The following is a description of a gene set: Binding to a DNA-binding transcription factor, a protein that interacts with a specific DNA sequence (sometimes referred to as a motif) within the regulatory region of a gene to modulate transcription. Mouse Gene Set: GOMF_DNA_BINDING_TRANSCRIPTION_FACTOR_BINDING studied in species Mus musculus, and this is the list of marker genes: Nhlh2, Med12, Nkx2-1, Gsk3b, Trp53bp1, Kmt2a, Ahr, Stat5b, Csrp3, H2bc23, Ar, Tbx5, Ywhah, Tcp10b, Ctbp2, Daxx, Bud31, Nbn, Fkbp4, Ipo13, Ifi27, Ttc8, Arrb1, Wipi1, Kat8, Cdk5rap3, Hcfc1, Tcerg1, Atf4, Smad3, Lmo2, Ankrd1, Flna, Mettl23, Lmo1, Taf4b, Rnf4, Lrif1, Ddx54, Ptprt, Nr1h3, Kat5, Cbx3, Mkks, Csnk2b, Psmc5, Src, Zfp703, Id4, Mef2c, Prrx1, Usf2, Jund, Cebpg, Prdm5, Nfyb, Ncapg2, Gbx2, Pramel13, Dll1, Nucks1, Sirt2, Hsd17b10, Ctcf, Lef1, Crebbp, Esr1, Nfatc1, Ski, E2f1, Setd6, Txlng, Rbx1, Klf5, Bcor, Prkdc, Gtf2i, Smarcd3 (NCBI Gene Id 78383), Hdac3, Map3k7, Ddx5, Trib1, Med1, Foxl2, Rbbp8, Sra1, Pias1, Bbs7, Kdm3a, Cebpb, H2bc9, Arnt, Npm1, Ets1, Hdac2, Gata6, Hey2, Epas1, Sox2, Crtc2, Lmo3, Hspa1a, Ankrd42, Hira, Tcf15, Flt3, Bmyc, Satb1, Gtf2a2, Sumo2, Tcp10a, Nkx3-1, Yap1 (yes-associated protein 1), Bex2, Arnt2, Creb3, Cnot7, Ptma, Bcl3, C1d, Tal1, Brms1, Park7, Rxra, Hmga1b, Sall1, Cited2, Mtdh, Wbp2, Zbtb17, Runx1t1, Cdkn2a, Hhex, Tbx2, Tcf7l2, Commd7 (COMM domain containing 7), Hes6, Prdm13, Bbs1, Fus, Hcls1, Fiz1, Dnaaf4, Gata1 (NCBI Gene Id 14460), Mad2l2, Sp1, Tpt1, Hnf4a, Crtc3, Tead3, Uhrf2, Faf1, Nr1i2, Tle4, Apex1, Sik1, Jun, Rbfox2, Tada3, Tbx20, Ncor2, Hdac1, Kat6a, Lhx3, Nup62, Trip4, Sp3, Smarca1, Zfpm1, Rnf25, Asah1, Uba3, Nfkbia, Bcl2, Lcor, Nrip1, Magea10, Usf1, Zbtb7a, Dhx33, Pitx1, Tcp10c, Sox8, Magea2, Mdfic, Id3, Smarce1, Nr1h2 (nuclear receptor subfamily 1, group H, member 2), Tcf3, Trim24 (tripartite motif-containing 24), Nfia, Rps6ka1, Bhlhe40, Myod1, Smad2, Hey1, Kpna2, Cpne1, Trp73, Bcas3, Chd4, Nr0b1, Hdac9, Wfs1, Ppid, Smarcb1, Parp1, Rnf6, Rest (RE1-silencing transcription factor), Arid5a, Tdg, Anxa4, Bcl11a, Mlxipl, Hoxa7, Magea5, Kat2b (NCBI Gene Id 320956), Runx1, Ascl2, Lrp2, Mixl1, Ctbp1, Taf9, Kdm1a, Noc2l, Med17, Nr4a1, Mdfi, Bbs2, Ywhaz, Lmo4, Gata2, Dhx9, Ddrgk1, Tfdp1, Zbtb49, Fbp1, Pagr1a, Nkx2-5, Lats1, Stat5a, T (brachyury, T-box transcription factor T), Nr4a2, Psma6, Zbtb8a (zinc finger and BTB domain containing 8a), Tcf4, Srarp, Notch2, Cggbp1, Ube2i, Bcl6, Isl1, Rarb, Nif3l1, Ifrd1, Pdcd11, Nrbf2, Cry2, Hif1a, Atf2, Pou4f1, Irx5, Prdm16, Foxa1, Vdr, Foxh1, Trim68, Stat3, Fam220a, Hsf1, Cnot1, Dapk3, Scx, Med24, Map3k10, Mms19, Ppara (peroxisome proliferator activated receptor alpha), Trip12, Cxxc5, Ankrd2, Trerf1, Nsd1, Hif1an, Trp53bp2, Tmf1, Grm1, Vhl, Thrap3, Nlrp3, Cbx5, Dnaja1, Ciita, Ep300, Cenpf, Nr1h4, Zfp473, Actn4, Wwp2, Purb, Taf12, Dusp26, Mlx (MAX-like protein X), Psmd9, Dcaf13, Rbx1-ps, Zfp653, Tbx6, Pbx2, Kdm4c, Nr4a3, Figla, Brd8, Tgfb1i1, Apbb1, Aip, Hr, Ccnt1, Sp100, Ddx20, Eomes, Bbs10, Pitx2, Hipk2, Taf10, Tcf23, Zfp366, Foxc1, Icmt, Hspa4, Prmt2, Gsc, Tacc1, Ppard, Fos, Foxp3, Twist1, Ncoa2, Sin3a, Med13, Keap1, Dhrs7b, Tbp (TATA box binding protein), Strn, Magea4, Mecr, Pou1f1, Eif4e, Myocd, Bhlhe41, Prkcb, Tob2, Tbx18, Calr, Snw1, Arid1a, Gtf2b, Hmgb2, Grhl2, Dnmt3a, Ncoa1, Ldb1, Sri, Ctdp1, Hdac5, Elk1, Zfpm2, Nr0b2, Ddit3, Ubxn7, Dmap1, Exosc9, Parp10, Bbs5, Ccdc62, H2bc24, Taf1, Hdac8, Mta2, Sox17, Dgkq, Fhl2, Smad4, Klf4, Kdm5c, Dcaf1, Stk4, Crkl, Pou5f1, Tbx3, Pbxip1, Cd34, Runx2, Hoxc13, Uimc1, Sost, Tcf21, Dnaja3, Crtc1, Rela, Psmd10, Ncoa7, Foxp1, Rfc1, Taf6, Pbx1, Rnf14, Ppargc1a, Commd6, Bcl10, Xpc, Foxo4, E4f1, Trim6 (tripartite motif-containing 6), Rxrb, Pparg, Mta1, Crx, Rps3, Yy1, Med16, Esrrb, Rad21, Tcf12, Arap1, Setd1a (NCBI Gene Id 233904), Gabarapl1, Grhl1, Srf, Xpo1, Taf4, Per1, Zfp516, Hdac7, Mkx, Sox10, Slc30a9, Ebf4, Parp9, Ikzf4, Nek6, Hdac11, Sox9, Spi1, Rbpj, Cry1, Prox1, Ets2, Mapk14, Ncor1, Trp53, Myc, Naaa, Dazap2, Ncoa6, Kdm5d, Hmga2, Chchd2, Nfe2l2, Neurod1, Asxl1, Psip1, Ppargc1b, Pik3r1, Id2, Ascl1, Mef2a, Akap8, Sirt1, Gmnn, Eef1d, Tle1, Magea3, Sry, Egr2, Gata4, Ncoa3, Med25, Pkn1, Bmal1, Rarg, Hspb1, Actb, Dtx3l (NCBI Gene Id 209200), Sub1, Pias2, Mef2d (myocyte enhancer factor 2D), Hmgb1, Smarca4, Sting1, Setd3, Nlk, Stat1, Psmc3ip, Dnmt1, Ascl5, Padi2, Gtf2a1, Hand2, Hand1, Spen, Taf7, Gtf2h1, Commd8, Max, Pura, Ptpn2, Pcna, Tox2 (TOX high mobility group box family member 2), Gfi1b, Creb1, Mapk3, Trib2, Hes1, Hdac4, Cebpa, Dact1, Atoh8, Rb1, Bex1, Chchd2-ps, Tacc2, Foxp2, Prpf6, Spop, Sdr16c5 (short chain dehydrogenase/reductase family 16C, member 5), Med30, Add1, Gata3, Jup, Lpin1, Hmga1, Med4, Bbs4, Dot1l, Rad23b, Klf1, Per2, Lyar, Taf11, Kat2a, Hspa1b, Nfkbid, Ctnnb1